Given this list of marker genes NRG1, BMP10, COL11A1, HEYL, BMPR1A, HIF1A, FOXH1, MYL3, CHD7, LRP2, MYH6, FOXC1, MYH7, POU4F1, HEY1, FOXC2, TNNI3, DSP, ENG, SMAD4, NPY2R, DLL4, HAND2 (heart and neural crest derivatives expressed 2), PROX1, MEF2C, TGFB2, SOX4, TBX20, MESP1, EDNRA, CPE, PPP1R13L, JAG1, TNNI1, SMAD7, ZFPM2, UBE4B, SEMA3C, MYL2, BMP4, FKBP1A, GRHL2, TGFB1, SMARCD3, NOG, TBX5, TGFBR2, GATA4, NAGLU, PTCD2, TNNT2, HEG1, MIR17HG, NKX2-5 (NK2 homeobox 5), RYR2, FOXF1, NOTCH1, SFRP2, PKP2, TGFBR3, EVA1A, HAND1, MED1, MYBPC3, HEY2, ISL1, GATA3, GSK3A, TPM1, NPY5R, TNNC1, FGFR2, RBPJ, TGFBR1, here is a description of the gene set: Human Gene Set: GOBP_CARDIAC_VENTRICLE_MORPHOGENESIS studied in species Homo sapiens The process in which the cardiac ventricle is generated and organized. A cardiac ventricle receives blood from a cardiac atrium and pumps it out of the heart.